Given this list of marker genes NOTCH2, SOX4 (NCBI Gene Id 6659), HEY2, MDM4, BMP2, SOS1, NOTCH1, PROX1, NKX2-5, NOG, MESP1, TBX20, ZFPM1, ACVR1, TGFB2, BMP10, ANK2, MDM2, DAND5, SHOX2, WNT2, BMPR2, MYH6, DLL4, GATA4, NPHP3, CCN1, WNT11, SMO, ISL1, PITX2, TBX5, NSD2, ENG, WNT5A, GJA5 (NCBI Gene Id 2702), HEG1, here is a description of the gene set: The process whose specific outcome is the progression of a cardiac atrium over time, from its formation to the mature structure. A cardiac atrium receives blood from a vein and pumps it to a cardiac ventricle. Human Gene Set: GOBP_CARDIAC_ATRIUM_DEVELOPMENT studied in species Homo sapiens